The following is a description of a gene set: Human Gene Set: GSE17721_CTRL_VS_POLYIC_6H_BMDC_UP from publication Amit I, Garber M, Chevrier N, Leite AP, Donner Y, Eisenhaure T, Guttman M, Grenier JK, Li W, Zuk O, Schubert LA, Birditt B, Shay T, Goren A, Zhang X, Smith Z, Deering R, McDonald RC, Cabili M, Bernstein BE, Rinn JL, Meissner A, Root DE, Hacohen N, Regev A (PMID 19729616) mouse primary BMDCs were stimulated with tlr ligands and gene expression changes were profiled on Affymetrix arrays species: Homo sapiens Genes up-regulated in comparison of control dendritic cells (DC) at 6 h versus those stimulated with poly(I:C) (TLR3 agonist) at 6 h., and this is the list of marker genes: C1QC, SLF2, NUCKS1, TAX1BP3, ENTREP3, H2BC5, SASH3, ADRB2, MCOLN1, CAPZA1, TAF10, CASP6, ATG12, SKP1, DDX41, USP11, ARHGDIB, NR1D2, WASF2, SUPT20H (NCBI Gene Id 55578), ARPC1A, CCT5, PABPN1, NEU1, SLPI, BCAP29, TACR3, PSENEN, CUTA, ZFAND2A, FUOM, LMNB2, ORMDL2, ALDOA, RABIF, CLPTM1L (NCBI Gene Id 81037), LZTR1, CCNI, RETREG2, TESK2, ASF1B (NCBI Gene Id 55723), SUPT5H, UBR1, MKNK2, SPG21, HMGCS1, TBC1D23 (NCBI Gene Id 55773), STMP1, CLIC1, TMEM141, ZNF703, FAM91A1, SIRT3, CETN2, STARD4, HCFC1, PDXK, AIRN, SPHK2, RNF149, MMD, RDM1, RCC1L, PGD, NUDT4, ANP32B, OAZ2, PTCD3, HAAO, EIF3H, GALNS, FFAR2, FAM111A, SLC39A4, IER2, RBBP7, ECHDC1, RP9, PDE8A, NDUFA2, SSR4, SCAF8, SELENOM, ZNF346, EIF3F, WDR45, MPV17, SC5D, OSBP, BCAP31, HIGD2A, SRF, RGS10, RPA2, PLA2G6, UBP1, XPC, IL6ST, GUSB, PDCL, NEDD1, PDLIM2, RPLP1, ZNF688, DMAC1, AP3B2, PEX2, NDST1, RPS15A, REV3L, FRAT2, SWSAP1, TBX21, VOPP1, ATP6V1C1, USF2 (upstream transcription factor 2, c-fos interacting), USP3 (ubiquitin specific peptidase 3), UBXN1, NIFK, UBE2I, NDUFA7, HCFC1R1, EMC2, PARVG, ZDHHC6, NFAM1, MRPL51, OTULIN, SPATS2, TLE2, SPC25, HEBP1, USP19, ARRB1 (NCBI Gene Id 408), LYSMD3, MAN2B2, CDK2, ARHGAP39, TMEM203, SFXN3, SH3BGR, QRSL1, TMEM179B, AKR1C3, CD48, BSG, NAGK, PLEKHG2, COMMD6, LAMTOR3, TSPAN14, TTI1, RPL41, ALDH3A2, DNAJB2, IQSEC1, IVNS1ABP, NAT9, CA1, PLSCR3, RAB40C, DNASE2B, NDUFB11, SEC16A, TMEM50B, UBAP1, UFSP2, ZNF566, NUMBL, NUFIP1, ELOVL6, IMP3, SLC26A6, AGGF1, CCNA2, RNH1, GCLM (NCBI Gene Id 2730), EBP, HNRNPU, ZNF841, RTCB, GALC, MACROD1, FTSJ1, PLXNB2, DPH7, RAP1A, EVI5, SOD1, CYBB, APLF, UQCRHL, ECH1, IPPK, NUP85, SRP68, MYRF (myelin regulatory factor), TALDO1